The following is a description of a gene set: studied in species Mus musculus Mouse Gene Set: REACTOME_COMPLEX_IV_ASSEMBLY Complex IV assembly, and this is the list of marker genes: Timm21 (NCBI Gene Id 73345), Cox14, Cox18, Cox19, Cox8c, Cox4i2, Cox16, Higd2a, mt-Co2, Cox6a1, Rab5if, mt-Co1, Coq10a, Cox4i1, Sco1, Cox11, Smim20, Cox6b1, Cox7b, Cox7a1, Coq10b, Ndufa4, Cox6c, Cox7c, Cox17, Cox6b2, Tmem177, Coa3, Cox20, Sco2, Cox8a, Cox7a2, Higd1a (NCBI Gene Id 80431), Cox15, Cmc1, Cox5b, Surf1, Coa5, Cox5a, mt-Co3, Cox6a2, Cox7a2l